The following is a description of a gene set: species: Mus musculus Mouse Gene Set: GOBP_REGULATION_OF_3_UTR_MEDIATED_MRNA_STABILIZATION Any process that modulates the frequency, rate or extent of 3'-UTR-mediated mRNA stabilization., and this is the list of marker genes: Larp4b, Elavl4 (ELAV like RNA binding protein 4), Qki, Tent4b, Arid5a, Tent4a, Rbm24, Mettl16 (methyltransferase 16, N6-methyladenosine)